The following is a description of a gene set: from publication Cipolletta D, Feuerer M, Li A, Kamei N, Lee J, Shoelson SE, Benoist C, Mathis D (PMID 22722857) Genes down-regulated in T reg cells from aged PPARG knockout mice: visceral adipose tissue versus lymph node. Human Gene Set: GSE37532_VISCERAL_ADIPOSE_TISSUE_VS_LN_DERIVED_PPARG_KO_TREG_CD4_TCELL_DN We identified Pparg as a major orchestrator of the phenotype of adipose-tissue resident regulatory T cells (VAT Tregs). To establish the role of Pparg in shaping the VAT Tregs gene profile and cell dynamics, Tregs from lymph nodes and visceral adipose tissue of mice sufficient and deficient of Pparg expression in Tregs were double sorted for microarray analysis. species: Homo sapiens, and this is the list of marker genes: TMEM44, CCDC97, ZNRF1, TMEM143, KRTAP1-3, MIR206, MC3R, SHISAL2A, TCF7, DENND1C, MED24, VPS33B, GPR12, HCRTR1, KMT2D, BUD13, ZFYVE1, UPF1, SNHG11, RASSF10, PITPNM1, RXRA, GATC, MFSD10, RGP1, DCP1A, KCNMA1, DHRSX, TFEB, TMED1, TET1, GNA12, NSUN3, PFAS, LHFPL2, INSYN2B, TADA3, KCNS2, TMEM106C, SNORA61, PIP5K1C, PRR14, NANOG, ADRA2B, CACNG1, TRAPPC9, TEF (NCBI Gene Id 85370), SLC29A3, ATG9A, CAMTA2, BICD2, RASSF2, ATF6B, SLC25A42 (solute carrier family 25 member 42), DHRS3, PLD3, NADSYN1, MBD6, AMDHD2, SH2B3, CNNM3, PEAR1, TMEM222, SPACA3, SNORA3A, MED26, FOSL2, REXO1, ENSG00000212553, ARID1A (AT-rich interaction domain 1A), NCLN, DOT1L, TSHZ2, SLC6A5, P4HTM, SYNGR1, SNORA73B, NAV2, ERN1, SNORA74A (small nucleolar RNA, H/ACA box 74A), INO80D, GGA1, TMEM67, ADGRL1, FAM193B, GRAMD1A, SETD1B, RNPEPL1, GPRIN1, PHF2, FURIN, ATP1B2, ZBTB5, RNF126, PNPLA6, SHISA2, SNORA75, IRF2, PLAC8L1, KREMEN1, MYO9B, SLCO3A1, YIPF3, PRICKLE3, ZSWIM4, HEY1, H1-2, CBARP, PPP1R11, GABBR1, BRINP2, MAP3K11, SELENOM, SPHK2, MTA3, SFXN3, SETD1A, FMC1, DENND6B (NCBI Gene Id 414918), PMM1 (phosphomannomutase 1), TMEFF2 (NCBI Gene Id 51753), MUC16, FLRT3, RHBDL1, ST6GAL2, LRP10, ARHGEF1, BACH2, PLPPR2, RANBP10, SCML4, NPEPL1, DLGAP3, ATG2A, TMEM150A, PCED1A, MAP3K13, NEU3, RFLNB